Given this list of marker genes ATIC, APOBEC3F, APOBEC3G, ADAT1, AMPD2, AICDA, DCTD, APOBEC3D, ADAT3, APOBEC2, ADARB2, ADA, MTHFD2L, AMPD3, APOBEC3C, CDADC1 (cytidine and dCMP deaminase domain containing 1), APOBEC1, ADA2, ADAR, APOBEC3A (NCBI Gene Id 91577), ADAD2, ADAT2, GCH1, APOBEC3H, MAPDA, ADAD1, AMPD1, MTHFD2, ADARB1, CDA, APOBEC3B, GDA, LACC1, GCHFR, MTHFD1, here is a description of the gene set: Human Gene Set: GOMF_HYDROLASE_ACTIVITY_ACTING_ON_CARBON_NITROGEN_BUT_NOT_PEPTIDE_BONDS_IN_CYCLIC_AMIDINES studied in species Homo sapiens Catalysis of the hydrolysis of any non-peptide carbon-nitrogen bond in a cyclic amidine, a compound of the form R-C(=NH)-NH2.